Given this list of marker genes RAF1, ARAF, CDC42 (NCBI Gene Id 998), MAP2K2, MAPK1, RAC1, MAPK3 (mitogen-activated protein kinase 3), PAK1, BRAF, MAP2K1, here is a description of the gene set: Pathway Definition from KEGG: (RAC1,CDC42) -> PAK1 -> RAF -> MEK -> ERK Human Gene Set: KEGG_MEDICUS_REFERENCE_RAC_CDC42_PAK_ERK_SIGNALING_PATHWAY RAC/CDC42-PAK-ERK signaling pathway. Pathway ID: N01119. Pathway type: Reference. Pathway class: nt06526 MAPK signaling. studied in species Homo sapiens